Given this list of marker genes ATN1, H4C5, KANSL1, BCOR, WAC, ARID1B, GJA5, LZTR1, ZNF292, CREBBP, CHD1, DDX59, FOXP2, ADNP, SLC35C1, CAPRIN1, CCDC22, DHX30, DEAF1, KDM6A (lysine demethylase 6A), RPS23, KMT2D, TBL1XR1, FOXP1 (NCBI Gene Id 87246), NXN, GJA8, EBF3, EMC1, TCF4, EZH2, EP300, HNRNPH2, TWIST2, PAK3, MED12, PKDCC, PRR12 (proline rich 12), KMT2A, JARID2, CTCF, RUSC2, KPTN, MED12L (NCBI Gene Id 57726), H3-3B, NR2F1, MAP1B, ZNF407, NAA10, NFIX, AHDC1, here is a description of the gene set: A soft tissue prominence of the ventral aspects of the fingertips or toe tips. Human Gene Set: HP_PROMINENT_DIGIT_PAD Prominent digit pad studied in species Homo sapiens